Given this list of marker genes IGFBP7, CYB5B, AIF1, PTPRCAP (NCBI Gene Id 5790), MX2, KCNAB2, TUBGCP3, SATB1, PAK1, MYB, GGT1, SRGN, RGS19, SNRPN, FUT4, here is a description of the gene set: from publication Ray S, Lu Y, Kaufmann SH, Gustafson WC, Karp JE, Boldogh I, Fields AP, Brasier AR (PMID 15155749) Chronic myelogenous leukemia (CML) results from a t(9,22) translocation, producing the p210(BCR-ABL) oncoprotein, a tyrosine kinase that causes transformation and chemotherapy resistance. To further understand mechanisms mediating chemotherapy resistance, we identified 556 differentially regulated genes in HL-60 cells stably expressing p210(BCR-ABL) versus those expressing an empty vector using cDNA macro- and oligonucleotide microarrays. These BCR-ABL-regulated gene products play diverse roles in cellular function including apoptosis, cell cycle regulation, intracellular signaling, transcription, and cellular adhesion. In particular, we identified up-regulation of the inducible form of heat shock protein 70 (Hsp70), and further explored the mechanism for its up-regulation. In HL-60/BCR-ABL and K562 cells (expressing p210(BCR-ABL)), abundant cytoplasmic Hsp70 expression was detected by immunoblot analysis. Moreover, cells isolated from bone marrow aspirates of patients in different stages of CML (chronic, aggressive, and blast crisis) express Hsp70. Expression of p210(BCR-ABL) in BCR-ABL negative cells induced transcription of the proximal Hsp70 promoter. Mutational analysis mapped the major p210(BCR-ABL) responsive element to a high affinity 5'(A/T)GATA(A/G)-3' GATA response element (GATA-RE) that binds GATA-1 in CML cells. The GATA-RE was sufficient to confer p210(BCR-ABL)- and p185(BCR-ABL)-mediated trans-activation to an inert promoter. Short interfering RNA mediated knockdown of Hsp70 expression in K562 cells induced marked sensitivity to paclitaxel-induced apoptosis. Together these findings indicate that BCR-ABL confers chemotherapeutic resistance through intracellular signaling to the GATA-RE element found in the promoter region of the anti-apoptotic Hsp70 protein. We suggest that down-regulation of the GATA-Hsp70 pathway may be useful in the treatment of chemotherapy-resistant CML. Human Gene Set: RAY_TARGETS_OF_P210_BCR_ABL_FUSION_DN species: Homo sapiens Genes down-regulated in HL-60 cells (acute myeloid leukemia, AML) by expression of p210 BCR-ABL fusion protein.